Given this list of marker genes HPCAL1, GLI2, RAB40B, ENSG00000273828, FLJ40288, RBFOX1, NMBR-AS1, IGLJCOR18, SLC35C2, MYLK3, HNRNPA3P17, HOXA2, LINC02054, here is a description of the gene set: Genes containing one or more binding sites for (FOXF2) in their promoter regions (TSS -1000,+100 bp) as identified by GTRD version 20.06 ChIP-seq harmonization. Human Gene Set: FOXF2_TARGET_GENES from publication Yevshin I, Sharipov R, Kolmykov S, Kondrakhin Y, Kolpakov F (PMID 30445619) species: Homo sapiens